Given this list of marker genes RNU6-2 (RNA, U6 small nuclear 2), CCL14, CRLS1 (NCBI Gene Id 54675), WDR97, PARP2, PHC3, RNVU1-26, RNU11, BCL3, CTBP2, SNORD118, ENSG00000261285, RFKP2, AHR, RNU4-1, RN7SK, DBNDD2, MIR5087, MT-TY, BLOC1S2, RNU1-1, MBL1P, FUS, RNU5E-1 (RNA, U5E small nuclear 1), RNU4-2, MAF1, TACC2, DNAJA1, SH3TC1, PDE4DIPP6, WDR74, UTP11, RNVU1-22, MIR342, RNU5E-4P, CCDC80, RNA5SP280, MT-TP, PDZD7, RNU5A-8P, ZNF587B, ADGB, ACTR10, MT-TA, MED16, C5orf24, PRAG1, CTSB, RNU5F-1, RNVU1-27, ADAM5, RNU1-2, RNVU1-14, RNU2-2P, RNY3, RNU5D-1, RNVU1-21, NWD1, RPPH1, MT-CO2 (NCBI Gene Id 4513), RNU5A-1, RNU6-1, RNU12, MIR4477B (NCBI Gene Id 100616194), TTI2, NPAS2-AS1, AGBL5-AS1, FUZ, SNORD13 (NCBI Gene Id 692095), LINC01015, RNVU1-3, PARN, AGBL5, TMEM259, RNY1, LINC01719, CSTF2, ACP6, GPAM, POLM, MTCO3P12, SREBF2, RNY4, MLIP, KRTAP5-6, RNU6ATAC, LNX1-AS1, EP300, RNU6-9, SLCO3A1, TGFB3, ZNF75A, MT-TD, ERICH3, RNU4ATAC, RNVU1-6, VPS39, RNU5E-6P, WBP2P1, GHET1, KHNYN, SAV1, ENSG00000259118, DUX4L50, SBK1, LINC00869, POLDIP3, EHD1, FASTK, RNVU1-2A, CLASP1, RNVU1-25, CBLN3, UNC13D, MT-TC, LMOD1, GPRIN2, RNU6-8, TSN, POLRMT, RMRP, RNVU1-31 (NCBI Gene Id 124904619), ERCC1, SMG9, KIF16B, PVT1, NUCB2, CCDC107, LINC01596 (NCBI Gene Id 105377617), GSTA4, RNVU1-2, RNU5B-1, RNVU1-28, RNVU1-30, SLC25A12, GRIN1, MT-TN (NCBI Gene Id 4570), CD163, RNU2-63P, here is a description of the gene set: from publication Yevshin I, Sharipov R, Kolmykov S, Kondrakhin Y, Kolpakov F (PMID 30445619) Genes containing one or more binding sites for (SNAPC4) in their promoter regions (TSS -1000,+100 bp) as identified by GTRD version 20.06 ChIP-seq harmonization. species: Homo sapiens Human Gene Set: SNAPC4_TARGET_GENES